Given this list of marker genes HOXA7, MIR29C (microRNA 29c), SRC, ITGB1BP1, CASK, ACVRL1, NF2, RASA1, SEMA3E, MMP12, CLASP2, DUSP22, MIR939, CDKN2A, PTEN, DLC1, PLET1, POSTN (periostin), APOD, BCL6 (BCL6 transcription repressor), MIR192, FAM107A, MIR92A1, AJAP1, PHLDB2, ACER2, CORO1C, SERPINE1, PIK3R1, JAG1, NEXMIF, DMTN, MYOC, THBS1, MAP4K4, ARHGAP6, NF1, ADAM15, MMP14, RCC2, here is a description of the gene set: Human Gene Set: GOBP_NEGATIVE_REGULATION_OF_CELL_MATRIX_ADHESION Any process that stops, prevents, or reduces the rate or extent of cell adhesion to the extracellular matrix. studied in species Homo sapiens